The following is a description of a gene set: Endocytosis of a protein that requires the substrate to be modified by ubiquitination. Several plasma membrane proteins, including cell surface permeases and some receptors, are targeted for internalization by endocytosis, and are thereafter delivered to the vacuole or lysosome, where they are degraded. studied in species Homo sapiens Human Gene Set: GOBP_UBIQUITIN_DEPENDENT_ENDOCYTOSIS, and this is the list of marker genes: NDP, CBL, EPS15, NEURL3, NEURL1B, VPS28, TSG101, LRSAM1, IL10RA